The following is a description of a gene set: Signaling processes are central to human physiology (e.g., Pires-da Silva & Sommer 2003), and their disruption by either germ-line and somatic mutation can lead to serious disease. Here, the molecular consequences of mutations affecting visual signal transduction and signaling by diverse growth factors are annotated. species: Homo sapiens part of: Disease Reactome Pathway: Diseases of signal transduction by growth factor receptors and second messengers, and this is the list of marker genes: RBPJ, FAM131B, IHH, UBA52, CNKSR1, CEBPB, CAMK2A, GSK3A, PSMD11, CBL, PTPN12, TNKS, ADRM1, NOTCH1, SEM1, HEYL, GZMB, SMAD4, KAT2B, AGO2, AMER1, DNMT1, FGF6, PPP2R5D, TCF7L2, CLTC, MOV10, BTC, AKT3, FGFR4 (NCBI Gene Id 2264), KITLG, FOXM1, TNKS2, POLR2H, TGFBR1, SHOC2, PSMD1, KIT, PIK3CB, GAB1, HDAC4 (histone deacetylase 4), BIN2, HDAC7, CD19, NOX4, TP53 (tumor protein p53), AGK, RPS6, PSMD8, PRF1, APC, CDC37, PHB1, MAML3, ICOS, GTF2F1, CTBP1, GOLGA4 (NCBI Gene Id 2803), CTNNB1, STAT3, DKK2, FLT3, RAC2, FGG, TGFBR2, EPGN, FGF3 (fibroblast growth factor 3), ACTB, KSR2, PSMC2, PTPN6, HEY1, FOXO3, PIM1, PRKAR1A, DUSP6, AGO4, MYO18A, PSMD3, UBC (NCBI Gene Id 7316), POLR2K, SHH, POLR2L, PSMA5, PIK3R1, PSMC4, PSMB7, PSMA7, STAT5B, AKAP9, POLR2E, EP300, LYN, TRAT1, PDGFA, FGB, TFG, KANK1, FGF16, CCNB1, WDR48, ITGA2B, ATG7, PIK3CG, TPM4, PIK3AP1, TLN1 (NCBI Gene Id 7094), TWIST1, PSMB2, PIK3R6, FYN, PSMD14, GOLGB1, HRAS, DUSP7, ESRP1, CUL1, AGTRAP, NCOR1, RPS27A, UBB, CUX1, VCP, PSMB4, PSMD13, ZC3HAV1, HDAC10, SPRED3, HEY2, MRAS, PSENEN, DKK1, KLB, PPP2R5E, TBL1XR1, PTEN, PSEN1, ALK, AGO3, TGFA, CALM1, CSK, PPFIBP1, RANBP2, HGF, PIK3R3, PORCN, AREG, PSMA6, RHOG, STAT5A, PSMC5, FZD4, EIF2AK3, MIB1, BRAP, STRN, FGF9, BDNF, FGA, NRG2, FGF7, PSMD6, FBXW7, LRP6, GRB2, PSMC6, PPP2CA, ITGB3, PIK3CA, CLCN6, MAP3K11, BCL2L1, CAMK2G, POLR2J, CAMK2D, BCL11A, RRBP1, ZMYM2, NTRK3, PAPSS1, PPP2CB, NRG4, PTPN11, APH1A, PSMA3, DUSP8, NCBP2, CASP9, SMAD3, GAB2, BCL2A1, PLCG1, ERBB2, HDAC1, MAPKAP1 (MAPK associated protein 1), MIB2, FZD5 (frizzled class receptor 5), EGF, WDCP, MAMLD1, SPRED1 (NCBI Gene Id 161742), DUSP16, IL10RA, PDPK1, FLT3LG, AP3B1, HDAC6, RICTOR, DHH, APBB1IP, GCC2, ESR2, CDKN1B, IRS2, FGF10, MAP2K2, LMNA, PPP1CB, TYK2, PSMB5, ERBIN, RBX1, POLR2I, PRR5, FAM114A2, BIRC6, FGF17, FRS3, LRP5, BAD, KL, FOXO6, POLR2G, DCTN1, AKT2, HBEGF, MET, FXR1, TGFB1, SQSTM1, JUN, PPP2R5C, MAP2K1, MYH9, HDAC2, PPM1B, SEL1L, RPS6KB2, HDAC5, JAG2, IL10, TNRC6C, DLL1, HES1, ARAF, RB1 (NCBI Gene Id 92728), SND1, PSMD2, FIP1L1, HDAC3, ADAM10, BCR, PSMC1, BCL2L11, NRG1, NTRK2, IRF4, PSMB6, AXIN1, ETV6, ERBB4, EEF1G, SPTBN1, PPP2R1A, JUNB, YES1, FGFR1OP2, NRAS, RAP1A, ESR1, NEURL1B, ACTG1, MDM2, APH1B (aph-1 homolog B, gamma-secretase subunit), NPM1, TENT4A, PSMA4, KREMEN2, SMAD2, MARK3, RAF1, POLR2C, FKBP1A, TSC2, CREBBP, CNTRL, HSP90AA1, MCL1, KSR1, MPRIP, PPP2R5A, VCL, ERLEC1, ZAP70, AKT1, KLC1, POLR2D, FGF20, MAML2, SNW1, DUSP9, RNF213, NCBP1, TPM3, LRRFIP1, NF1, HDAC9, NCOR2, TRAK1, SEC31A, NTF3, HIP1, CCNC, FGFR1, FGF23, FGF8, FGFR2, BAG4, POLR2B, GTF2F2 (general transcription factor IIF subunit 2), ZC3HC1, VAV1, KRAS, PPP1CC, PSMD7, FGF19, SYVN1, PSEN2, MAPK9, PDGFRA, JAG1, FGF18, PDGFRB, FGF1, ARRB2, EGFR, CAMK2B, RAC1, KDM7A, FZD8, MSN, NEURL1, PSMA1, HHAT, PSMB1, KIAA1549, CEP43, FGF5, SRC (NCBI Gene Id 6714), CREB1 (NCBI Gene Id 1385), PSMD12 (NCBI Gene Id 5718), SPRED2, MIR21, MAPK8, BRAF, CPSF6, CTBP2 (NCBI Gene Id 87435), NR4A1, CDK8, DUSP10, LMO7, AGO1, POLR2A, FGF2, CD86, FGF22, DERL2, MECP2, LCK, CLIP1, JAK2, PDGFB, DLL4, OS9, AKT1S1, ZFYVE9, HES5, ADAM17, MLST8, MAML1, CARS1, FZD6, YWHAB, AGGF1, NCSTN, ARRB1, RNF43, FGF4, CNKSR2, HDAC11, RAP1B, ERLIN2, MYC, CDKN1A, PIK3R2, SHC1 (NCBI Gene Id 6464), QKI, TBL1X, MAPK1, KREMEN1, IQGAP1, TRIP11, STAT1, CHUK, PPP2R5B, FOXO4, KDR, CD28, ERBB3, DKK4, SKP1, PSMA2, FOXO1, EREG, NRG3, POLR2F, CD80, TPR, NTF4, KAT2A, PSMC3, CSNK1A1, TRIM24, FGFR3, PEBP1, PSMB3, GSK3B, SOS1, PIK3CD, IL22, ATIC, VWF, EML4 (EMAP like 4), FRS2 (fibroblast growth factor receptor substrate 2), FN1, IRS1 (NCBI Gene Id 3667), WNT3A, HDAC8, PIK3R5, PPP2R1B, KIF5B, MTOR, MAPK3 (NCBI Gene Id 5595)